The following is a description of a gene set: Ophthalmoparesis Human Gene Set: HP_OPHTHALMOPARESIS Ophthalmoplegia is a paralysis or weakness of one or more of the muscles that control eye movement. species: Homo sapiens, and this is the list of marker genes: POMGNT1, NDUFS1, OPA1, SUCLA2, ISCU, ARHGEF18, SNAP25, IMPDH1, COL25A1, CHRNE, HACD1, TSPYL1, RILPL1, STUB1, BEST1, MCM3AP, TPM2, UGT1A1, TERT, CC2D2A, SPATA7, AFG3L2, SNRNP200, SEMA4A, STIM1, COL3A1, NTNG1, SMARCE1, AHI1, RBP3, DOK7, HLA-B, TUB, NRAS, FA2H, TPK1, ENG, MERTK, FRG1, USH2A, HGSNAT, NFU1, ROM1, VARS2, CACNA1S, GPR101, MPV17, RRM2B, MAP3K20, KCND3, TYMP, CFAP418 (NCBI Gene Id 157657), KIF21A, MTOR, NUTM2B-AS1, SAG, MT-TH, NEK2, REV3L, IFT88, CDKL5, ATXN1, ATXN7, IDH3A, DHDDS, CHRNB1, REEP6, MICU1, ACTA1, ITGA7, TRAF7, PLEC, SLC25A1, PCYT1A, HRAS, LIG3, BBS1, WFS1, TMEM67, MT-TW, MTTP, KLHL40, ATN1, NSUN3, ARL3, UCHL1, P4HA2, NR2E3, CRB1, HLA-DRB1, TWNK, SCN4A, POLRMT, ATP5F1E, SMARCB1, RNASEH1, MT-ND5, MTMR14, CNGA1, MT-TV, MT-TQ, BBS2, CLRN1, MGME1, CHRND, TUBA1A, ZNF513 (zinc finger protein 513), RDH12, MYMK, ADPRS, MT-ND4, RP1L1, GABBR2 (NCBI Gene Id 9568), MT-ATP6, MT-ND6, TPM3, C1QBP, CA4, MYO9A, EARS2, RP9, TCIRG1, DHX37, POLG, GABRA3 (NCBI Gene Id 2556), DNM1L (dynamin 1 like), NF2, SLC7A14, MUSK, LRP12, LAMB2, SDHA, KIAA1549 (NCBI Gene Id 57670), TGM6, DNM2, LYRM7 (LYR motif containing 7), PRPF31, MT-ND3, AGRN, TUBB3, ABCB7, TAMM41 (TAM41 mitochondrial translocator assembly and maintenance homolog), MEN1, NADK2, MFF, DGUOK, TRPV4, CERKL, COLQ, VAMP1 (vesicle associated membrane protein 1), EYS (NCBI Gene Id 8414), FSCN2, IFT172, RP2, MECP2, RPGR, NRL, CRX, AHR, ATXN3, TEFM, PTPN22, SYT2, ATP5F1A, CDH23, LAMA2, MT-CO1, PIEZO2, PDE6A, RPE65, DNA2, MT-TL1, SPEG, NDUFV1, IMPG2, SLC18A3, ZNF408, SALL4, PROM1, AKT3, DHX38, IMPG1, CHRNA1 (NCBI Gene Id 1134), MT-CYB, ATP5F1D, KLHL41, FAM161A, RGR, PRCD, TULP1, PMPCA, MAK, MAFB, BAP1, MT-ATP8, PRPF8, NOTCH2NLC, CISD2, RLBP1, MT-CO3, GUCA1B, MYF5, CHN1, SDHD, PABPN1, ARL6, MT-TK, ARL2BP, ATP5MK, APTX, ATG7, GSN, MT-TT, GBA1, AGBL5, ABCA4, GFPT1 (NCBI Gene Id 2673), PRPF3, MAPT, TOPORS, MYL2, MT-ND2, ANGPTL6, SBF1, GIPC1, SDHB, SLC9A6, SMO, SYNE1 (spectrin repeat containing nuclear envelope protein 1), LRP4, ALDH4A1, SELENON, RP1, SLC19A3, PIK3CA, MT-ND1, COL13A1, NDUFAF2, CHAT, PDE6B, PRPF6, PDGFB, MT-TF, PHOX2A, ROBO3, MYF6, MT-CO2, TOP3A, HNRNPA2B1, KIZ, TTN, IDH3B, ATXN2, BIN1, HPDL, MT-TN, TUBB2B, PRPF4, SLC52A3, OFD1, TTC8, SLC5A7, ATPAF2, MT-TS2, TGFBR3, RYR1 (NCBI Gene Id 906), NEB, AK9, SURF1, PLXND1, AKT1, SLC25A4 (solute carrier family 25 member 4), THSD1, RRM1, RAPSN, MYH2, PRPH2, POLG2, NAXD, SUFU, KRAS, MTRFR, ACTN2, KCNJ18, ACADS, COX16, LRAT, TK2, MTM1, CNGB1, ADA2, SDHAF1, AIP, PCARE, MT-TC, SCAPER, RHO, SMC1A, CDHR1, MT-TL2, GRIN1, LMOD3, PDE6G, KLHL7 (NCBI Gene Id 55975), IFT140